The following is a description of a gene set: Any process that stops, prevents or reduces the frequency, rate or extent of neutrophil migration. studied in species Homo sapiens Human Gene Set: GOBP_NEGATIVE_REGULATION_OF_NEUTROPHIL_MIGRATION, and this is the list of marker genes: MIR223, DPP4, TNFAIP6, SLAMF8, SLIT2, C5AR2